Given this list of marker genes TERF1, PPP1R3F, FLVCR1, PSMG3-AS1, IL3RA, DSCC1, here is a description of the gene set: BACKGROUND: Live attenuated influenza vaccine (LAIV) and trivalent inactivated influenza vaccine (TIV) are effective for prevention of influenza virus infection in children, but the mechanisms associated with protection are not well defined. METHODS: We analyzed the differences in B-cell responses and transcriptional profiles in children aged 6 months to 14 years immunized with these 2 vaccines. RESULTS: LAIV elicited a significant increase in naive, memory, and transitional B cells on day 30 after vaccination, whereas TIV elicited an increased number of plasmablasts on day 7. Antibody titers against the 3 vaccine strains (H1N1, H3N2, and B) were significantly higher in the TIV group and correlated with number of antibody-secreting cells. Both vaccines induced overexpression of interferon (IFN)-signaling genes but with different kinetics. TIV induced expression of IFN genes on day 1 after vaccination in all age groups, and LAIV induced expression of IFN genes on day 7 after vaccination but only in children < 5 years old. IFN-related genes overexpressed in both vaccinated groups correlated with H3N2 antibody titers. CONCLUSIONS: These results suggest that LAIV and TIV induced significantly different B-cell responses in vaccinated children. Early induction of IFN appears to be important for development of antibody responses. Genes up-regulated in blood 30d vs 0d in children (0.5-14y) after exposure to FluMist, time point 30D. Comment: ~80% of cohort were white, ~50/50 Female:male Human Gene Set: CAO_BLOOD_FLUMIST_AGE_05_14YO_30DY_UP from publication Cao RG, Suarez NM, Obermoser G, Lopez SM, Flano E, Mertz SE, Albrecht RA, García-Sastre A, Mejias A, Xu H, Qin H, Blankenship D, Palucka K, Pascual V, Ramilo O (PMID 24495909) species: Homo sapiens